The following is a description of a gene set: The series of molecular signals initiated by a ligand binding to the endolysosomal toll-like receptor 8. Human Gene Set: GOBP_TOLL_LIKE_RECEPTOR_8_SIGNALING_PATHWAY species: Homo sapiens, and this is the list of marker genes: TLR8, MYD88, SLC15A4, TLR7, DDX3X, TASL